The following is a description of a gene set: Human Gene Set: GOBP_REGULATION_OF_CELL_COMMUNICATION_BY_ELECTRICAL_COUPLING_INVOLVED_IN_CARDIAC_CONDUCTION Any process that modulates the frequency, rate or extent of cell communication by electrical coupling involved in cardiac conduction. species: Homo sapiens, and this is the list of marker genes: TBX5, IRX3, PDE4D, CALM3 (calmodulin 3), GJD3, HRC, CALM2, TRDN, SRI (NCBI Gene Id 6717), CAV1, CALM1, CAMK2D